The following is a description of a gene set: The compaction of chromatin into a conformation that is refractory to transcription but that can be converted to euchromatin and allow transcription in specific contexts. These can be temporal (e.g., developmental states or specific cell-cycle stages), spatial (e.g., nuclear localization changes from the center to the periphery or vice versa due to exogenous factors/signals), or parental/heritable (e.g., monoallelic gene expression). In metazoa, this involves the methylation of histone H3K27. Mouse Gene Set: GOBP_FACULTATIVE_HETEROCHROMATIN_FORMATION species: Mus musculus, and this is the list of marker genes: Phf2, Sirt1, Eed (embryonic ectoderm development), Bend3, Baz2a, Suv39h1, Rrp8, Kdm5a (lysine demethylase 5A), Sirt2, Ehmt1, Smarca5, Ezh2, Phf8, Ezh1, Jarid2, Suz12